Given this list of marker genes BAX, GPER1, MMP9, BNIP3, PLAUR, TNFSF10, MOAP1, BAD, BMF, BCL2L11, MLLT11, TP53, FAM162A, BIK, PINK1, PYCARD, BID, BAK1, HRK, BBC3, PMAIP1, here is a description of the gene set: Human Gene Set: GOBP_POSITIVE_REGULATION_OF_RELEASE_OF_CYTOCHROME_C_FROM_MITOCHONDRIA species: Homo sapiens Any process that increases the rate, frequency or extent of release of cytochrome c from mitochondria, the process in which cytochrome c is enabled to move from the mitochondrial intermembrane space into the cytosol, which is an early step in apoptosis and leads to caspase activation.